Given this list of marker genes SSU72, NEK7, ICAM1, PSEN2, IZUMO1R, NIT1, SH2B1, LKAAEAR1, SCAMP1, FJX1, GPHN, CD164L2, TNNC1, F10, RFX5, LRRCC1, TUBB6, CAPN3, SLC9A5, NMI, IFTAP, TNFRSF18 (NCBI Gene Id 8784), TRMT13, PLD3 (phospholipase D family member 3), ITM2C, LIF, ABTB1, IL6ST, GPBP1, WAC, STX11, PLA2G3, CD48, RIPOR3, NFAT5, ELL2, KANK4, INSYN2B, PLAGL2, LYPLAL1, FBH1 (NCBI Gene Id 84893), RGS1, CFAP410, RPS6, TNFRSF4, PALLD, AIFM2, MOB3A, DSCAML1, HM13, KCNV1, DMRTA2, KLHL36, PRSS22 (NCBI Gene Id 64063), PSD3, ZBTB20, DECR2, CHST15, CCDC88B, SCN1B, TNFRSF9, CCS, SMPD3, SPRN, B3GNT2, KDSR, HLF, SLC44A1, ACTR3B, MAGEH1, REX1BD, WDR19, MAP4K5, MXD1, EVI5, ARL5A, IRAK1BP1, MARCHF11, ZC3H12D (NCBI Gene Id 387078), IFT57, CYB561A3, PHACTR1, WNT3A, PRPS2, INPP5A, PTGFRN, AVEN, CD37, ACBD4, ARV1, TST, LAPTM4A, ZBTB48, FAM193B, TK2, FAM120C, ZC3H11A, GRK4, ACOT9, F5, STYXL1, PGS1, PNOC, HHIPL1, EFS (embryonal Fyn-associated substrate), HPGDS, MRI1, UBASH3B, UBE2D3, GADD45B, TMEM130, KLHL10, DBNDD2, FAM167B, ITGAE, OPHN1, UAP1L1, ERCC4, AMBRA1, FARS2, FAM53C, RASGRP4, SFXN4, HSD3B7, SDC4, MICALL1, C16orf74, ERP44, TIAL1, SLC5A11, VPS72, IGFLR1, VAV3, CRCT1, RASGRF2, AADAC, ADAMTS6, HECTD2, EXOC2, PPP1R16B, PAPLN, SYNE4, ERN2, ATOSA, PTCD1, PLGRKT, LRRC61, IER5, FRMD6, PBX4, ACER2, CD81, ALDH7A1, CTSV, TTLL4, CSRNP1, SERPINB6, ADRB1, HSD17B2 (hydroxysteroid 17-beta dehydrogenase 2), SERPING1, ARL8B, GALNT15, TAPBPL, AFTPH, ATP6V1E2, PKN3, TM7SF3, CYP11A1, TRAPPC5, TBC1D2B, SNRNP27, AMBN, IL2RA, CSNK1G3, STXBP2, FBXL17, MMP9, CERK, NIBAN1, GIMAP5, HEXA, CNN1, ZNF646, FIRRE, SLC35D3, ELOVL6, RTP3, DECR1, SARAF, CNPY1, CFTR, FAM174A, TMED4, LY6K, MRGPRE, PEAK1, TP53I11, WDFY2, IRF6, AGT, here is a description of the gene set: Genes down-regulated in comparison of CTRLrv versus FOXP3rv (see Fig. 1 for details). Human Gene Set: GSE7460_CTRL_VS_FOXP3_OVEREXPR_TCONV_1_DN The transcription factor Foxp3 is usually considered the master regulator for the CD4+CD25+ studied in species Homo sapiens from publication Hill JA, Feuerer M, Tash K, Haxhinasto S, Perez J, Melamed R, Mathis D, Benoist C (PMID 18024188)